The following is a description of a gene set: Mouse Gene Set: GOBP_POSITIVE_REGULATION_OF_STRESS_ACTIVATED_PROTEIN_KINASE_SIGNALING_CASCADE studied in species Mus musculus Any process that activates or increases the frequency, rate or extent of signaling via the stress-activated protein kinase signaling cascade., and this is the list of marker genes: Pdcd10, Tgfb2, Taok3, Stk25, Scimp, Sema4c, Clec7a, Nod1, Mapk8ip2, Il1a, Igfbp6, Card9, Arl6ip5, Hmgcr, Ripk2, Mid1, Crhr2, Il1b (interleukin 1 beta), Nod2, Tlr4, Eif2ak2, Klhdc10, Inava (innate immunity activator), Taok1, Taok2